The following is a description of a gene set: Human Gene Set: REACTOME_REGULATION_OF_EXPRESSION_OF_SLITS_AND_ROBOS species: Homo sapiens Regulation of expression of SLITs and ROBOs, and this is the list of marker genes: RPL12, RPL9, PSMB7, GSPT2, RPLP0, RPS27A, RPL22, CASC3, RPL17, PSMD12, RPL6, ETF1, RPL7A, ROBO3, COL4A5, RPS24, RPL8, RPL11, PSMD1, EIF4G1, RPS19, RPL18, RPS10 (NCBI Gene Id 6204), PSMD8, RPL32, PSMC6, PSMD14 (NCBI Gene Id 10213), PSMB2, RPL26 (NCBI Gene Id 6154), RPS29, PSMD6, MAGOHB, PSMA1, RPL39L, UBB, RPL34, PSMA5, RPS5, PSMC1, RPL36AL, RPL35A, PSMC5, RPSA, UPF3B, SLIT2, ELOC, LHX4, ROBO1, LHX9, DAG1, RPS12, RPS7, RPS8, RNPS1, LHX3, PSMD2 (proteasome 26S subunit ubiquitin receptor, non-ATPase 2), RPL21, RPL10L, RPS2, RPS16, RPL23A, RPL23 (NCBI Gene Id 9349), RPL10 (NCBI Gene Id 88324), RPS13, RPS4Y1, UPF2, RPL37A, UPF3A, ADRM1, NCBP1, PSMA7, RPL15 (ribosomal protein L15), RPL10A, PSMB4, PSMC4, PSMD13, PSMA3, RPL36, RPS3, PSMC3, HOXA2, RPS4X, RPS9, RPL31, NCBP2, SEM1, RPL27, RBX1, USP33, UBA52, MSI1, RPL41, RPL3L, LDB1, ELOB, RPL30, RPL5, GSPT1, RPS27, RPS15, RPS15A, RPL19, RPS26, RPS20, MAGOH, RPS6, LHX2, PSMB3, PSMB6, RPS4Y2, RPS21, RPS27L, RPL7, SLIT1, RPL4, RPL22L1, RPS3A, PSMD3, RPL38, PSMB5, RPL35, EIF4A3, PSMA4, RPL28, RPS25, ISL1, RPL29, RPL14, ZSWIM8, PSMB1, PSMD7, RPL13, RPL37, PSMA6 (proteasome 20S subunit alpha 6), RPS14, RPL27A, RPS28, RPL3, RPS11, RPS23, RPL26L1, RPLP1, RPL24 (NCBI Gene Id 6152), PSMC2, RPLP2 (ribosomal protein lateral stalk subunit P2), ROBO2, RPL36A, RBM8A, PSMA2, RPS18, RPS17, RPL39, RPL18A (NCBI Gene Id 6142), RPL13A, CUL2, FAU, PABPC1, PSMD11, UBC